Given this list of marker genes KAT2B, WDR75, METTL18, YTHDF2, RIOK1, TRMT112, RIOK2 (NCBI Gene Id 55781), BUD23, NUDT16, USP36, HEATR1, UTP15, DIMT1, WDR43, SIRT7, here is a description of the gene set: species: Homo sapiens Any process that modulates the frequency, rate or extent of rRNA processing. Human Gene Set: GOBP_REGULATION_OF_RRNA_PROCESSING